The following is a description of a gene set: Conventional histology failed to classify part of non-medullary thyroid lesions as either benign or malignant. The group of tumours of uncertain malignancy (T-UM) concerns either atypical follicular adenomas or the recently called 'tumours of uncertain malignant potential'. To refine this classification we analysed microarray data from 93 follicular thyroid tumours: 10 T-UM, 3 follicular carcinomas, 13 papillary thyroid carcinomas and 67 follicular adenomas, compared to 73 control thyroid tissue samples. The diagnosis potential of 16 selected genes was validated by real-time quantitative RT-PCR on 6 additional T-UM. The gene expression profiles in several groups were examined with reference to the mutational status of the RET/PTC, BRAF and RAS genes. A pathological score (histological and immunohistochemical) was estimate for each of the T-UM involved in the study. The correlation between the T-UM gene profiles and the pathological score allowed a separation of the samples in two groups of benign or malignant tumours. Our analysis confirms the heterogeneity of T-UM and highlighted the molecular similarities between some cases and true carcinomas. We demonstrated the ability of few marker genes to serve as diagnosis tools and the need of a T-UM pathological scoring. from publication Fontaine JF, Mirebeau-Prunier D, Franc B, Triau S, Rodien P, Houlgatte R, Malthièry Y, Savagner F (PMID 17968324) Genes down-regulated in thyroid tumors of uncertain malignancy (T-UM) compared to other thyroid tumors. Human Gene Set: FONTAINE_THYROID_TUMOR_UNCERTAIN_MALIGNANCY_DN studied in species Homo sapiens, and this is the list of marker genes: IFITM3, LILRB3, ITGA4, IGSF10, CD38, TWIST1, VAV2, TRAF5, BAP1, FRZB, ODAM, PPIL4, IL24, KLF1, CD274, KIZ, ATR, SLPI, PCSK6, KLK2, HCLS1, ROGDI, PTGES, S100A10, IL2RA, PLCG2